The following is a description of a gene set: Abnormal abdomen morphology species: Homo sapiens Human Gene Set: HP_ABNORMAL_ABDOMEN_MORPHOLOGY A structural abnormality of the abdomen ('belly'), that is, the part of the body between the pelvis and the thorax., and this is the list of marker genes: HAVCR2, ABCB11, KIF20A, MTX2, ZEB2, PLAAT3, PALB2, USB1, PDGFRB, AGGF1, NGLY1, HJV, DYNC2LI1, TSC2, RABL3, ASAH1, BCL11A, ADA, LACC1, FGA, SLC7A7, BCL2 (NCBI Gene Id 596), VPS33A, TERT, GBA1, WDR1, MT-ATP8, SLC35C1, COX14, SAMHD1, ERCC8, UNC13D, LTBP3, LYST, G6PC1, LMNA, CCR1, DPM2, GATA2, CD40LG, TLR8, GAA (NCBI Gene Id 2548), FAM111B, PMM2, PIGS, SOX10, CCDC115, CBS (cystathionine beta-synthase), ABCG5, CD27, FANCD2, BRCA1, C2orf69, SPTBN1, NDUFS7, MYO5B, TKT, FBP1, BSCL2, ETFA, ATP8B1, PGM1, CTC1, GNA11, ATPAF2, G6PC3, CYBA, SLC19A1, AMACR, TREX1, NOTCH1, POU2AF1, SPIN4, ALDOB, EPB41, MT-ATP6, LCK, GALM, HBG1 (hemoglobin subunit gamma 1), TRIP13, MKS1, CTNS, TYMS (NCBI Gene Id 7298), SLCO2A1, GLB1, ARG1, IL18BP, PSMB8, ATRX, CD247, RFC2, TMEM67, GUCY2D, LIPA, NAE1 (NEDD8 activating enzyme E1 subunit 1), MCM4, NFKB1, PKLR, EPOR, BCL6, OCLN, SKIC3, SNX10, GPR35, FH, PHKB, HMOX1, RIPK1, CNTNAP2, TNFRSF1B, MYL2, PDCD1, NDUFB10, LIN28B, PIK3CA, TNFSF11, TPP2, TMEM165, VPS37D, CCDC47, GTF2IRD1, SLC25A15 (solute carrier family 25 member 15), POU6F2, ALG2, SLC34A2, NDUFS4, DOCK11, BPGM, HIRA, LYRM4, CYBC1, TSC1, CAVIN1, TNFRSF9, ALG8, MYPN, FOXRED1, PUS7, TRPV6, ARL6IP6, MVK, RNU7-1, SLC2A2, LRBA, MIF, MMACHC, KCNQ1OT1, NAGA, RREB1, ATP5MK, PEX19, BRCA2 (BRCA2 DNA repair associated, NCBI Gene Id 82716), PEX5, NRAS, FASLG, JMJD1C, HAMP, IKZF3, BAP1, ALG13, COX10, HSD3B7, SLC25A13, LCAT, DPM1, DNAJC21, MPV17, ZAP70, BBS12, SLC37A4, EXTL3, ETFDH, ABHD5, B4GALT1, NSD2, DKC1, PTPN11, SPTB, MT-TK, JAK1, PRF1, HNF1A, PIEZO1, FLI1, FOCAD, KDM6A, PHYH, PSMG2, GALK1, C4A, NDUFA1, VPS11 (VPS11 core subunit of CORVET and HOPS complexes), TNFRSF4, SMAD3, CPT2, AGA, SRP54, ABL1, BCR, MT-ND5, BTNL2, YARS1, TMEM70, EIF5A, PEX16, RPS26, MCOLN1, INPP5E, PHOX2B (NCBI Gene Id 8929), PIBF1, KCNN4, SOS1, SAT1, RAB27A (RAB27A, member RAS oncogene family), PEX26, SEC23B, TCF3, NLRP1, NOP10, AKT1, ATAD3A, SOX18, OAS1, CD96, SPP1, ATP7B, PEX2, MT-TL1 (NCBI Gene Id 4567), SOS2 (NCBI Gene Id 96829), ITCH, MT-TN, MAP2K1, SLC2A1, NAGLU, LAMA5, SEC63 (SEC63 homolog, protein translocation regulator), TIMMDC1 (translocase of inner mitochondrial membrane domain containing 1), TERC, GLRX5, ADA2, JAM3, FERMT3, PYGL, LARS2, CARD11, CBL, STAT4, AGL, GNMT, XPR1, PLEKHM1, AKT2, BACH2, CHD7, LARS1, SPIB, STXBP2, CASK, MMAB (metabolism of cobalamin associated B), BAAT, USP53, DLD, PDGFRA, DHFR, LIPE, DLL4, HGSNAT, IRF1, SLC29A3, NCF2, GATA1, BMP2, MT-TV, PRKAR1A, THSD1, GPC4, TGFB1, GPI, WT1, TULP3, TNPO3, AGR2, HSD17B4, LPL, TFE3, GNE, MPL, RINT1 (NCBI Gene Id 60561), NAB2, HACE1, KPTN, LZTR1, EIF2AK3, NDUFAF4, PNP, IFIH1, ASS1, CYP2R1, NUBPL (NUBP iron-sulfur cluster assembly factor, mitochondrial), VPS13A, POT1, EIF4H, TRMU, PEX3, FMO3, GP1BA, SOCS1, NDUFAF3, DZIP1L, TRAC, ICOS, IFT122, BAZ1B, RASA2, GTF2IRD2, SUCLG1, DOCK6, PPARG, ALDH1A2, UFD1, IL6ST, VIPAS39, ATP5F1D, GCLC, IL2RB, STAT1, MRPL3, BUB1B, DCDC2, NR1H4, DNAJC30, HLA-DRB1, FCHO1, H19, SGSH, MS4A1, C1QBP, SH2B3, UROD, CSF3R, NDUFA6 (NCBI Gene Id 4700), COL18A1, IFNG, PRKCD, GEMIN4, TMEM199, KIF1B, ARVCF, MED12, RPGRIP1L, CASR, NDUFS1, UMPS, RNF31, AHDC1, MADD, LRP5, DOCK2, ZIC3, HBA1, PNPLA2, MARS1, PSMB10, MMEL1 (membrane metalloendopeptidase like 1), MET, NAGS, SPINT2, CYP7B1, RTL1, XIAP, PARN (poly(A)-specific ribonuclease), USP18, IL2RA, SLC40A1, PTH1R, FGFR2 (NCBI Gene Id 2263), BUB1, IFT140, IFNGR1, CD81, STAT6, MYD88, NDUFAF5, IL12A, TNFRSF11A, MPIG6B, IDS, CR2, RFXAP, PSMB4, COA8, COX5A, NDUFAF2, KCNJ11, SLC25A1, ABCC6, ABCG8, ADRA2A, TBX1, RIT1, XK, PEX7, ROR2, NPHP3, IL12RB1, NDUFB11, STIM1, PRG4, BUD23, FAT4, MAN2B1, IFT172, FOXC2, ALK, YME1L1, BTD, SLC25A20, KCTD1, SPRED2, RBPJ, NDUFB3, PSMB9, LAT, LSM11, TRAPPC11, AGPAT2, ZFYVE19, TPI1, PIGM, NLRP12, UBR1, MAGT1, EPHB4, ERBB3, RAC2, SEMA4D, SLC4A1, IKBKG, LIMK1, DCLRE1C, MT-ND3, NDUFAF1, ACADVL, VPS4A, LTBP4, PTPN22, RHD, XYLT1, PKHD1, SCO2, MRPS7, GALE, NLRP3, ELN, PEX13, AP3D1, TFAM, ADAMTSL2, STX11, ATP5F1A, PCCA, EARS2, COG7, EWSR1, NDUFS2, SERPINA1, ANKRD55, ZNF699, AP3B1, GNPTAB, CA2, GNS, CCND1, CD19, RHAG, NDUFV2, EPB42, PRDX1, MT-ND1, GBE1, IL2RG, RNASEH2A (NCBI Gene Id 10535), TBK1, TNNT2, CEP57, KRAS, STX5, ANTXR1, KCNH1, HBA2, INSR, TCIRG1, MTTP, PLVAP, KLRC4, SPTA1, NDUFB9, ASXL1, KMT2D, TNNI3 (NCBI Gene Id 7137), MMAA, OTC, ACADM, MCTS1, SLC38A3, PIK3R1, CDKN1C, ARSB, F5, RFX6, PIK3CD, PHEX, MT-ND4, UQCRB, BOLA3, GTF2I, POLG, NFKB2, EOGT, TBL2 (NCBI Gene Id 27203), TALDO1, HMGCS2, ATP5F1E, DIS3L2, TOGARAM1, ITGA6, FAS, SASH3, MRPS28 (mitochondrial ribosomal protein S28), MICU1, SLC30A10, MAPK8IP3, KIT, FUCA1, FBN1, ITK, RTEL1, PCK1, SLC25A19, IL23R, MECOM, FARSA, PHKA2, NDUFA11, ETFB, WDR35, THPO, NPM1, TKFC, CSPP1, ANK1, AUH (AU RNA binding methylglutaconyl-CoA hydratase), ABCB4, ESCO2, TRNT1, ALAS2, CD70, MT-CYB, TLR4, LYN, NDUFV1, HMGCL, MT-TE, RAF1, MPC1, GNB2, MRPS22, NHLRC2, SEC24C, NLRC4, FARSB, RNASEH2B, FOS, SF3B1, CAV1, NEU1 (neuraminidase 1), NPC2, TSFM, BUB3, AKR1D1 (aldo-keto reductase family 1 member D1), MTO1, DHDDS, MFN2, RFT1, COMT, MEG3, GPC3, ADAMTS3, HLA-B (NCBI Gene Id 730410), ATP6AP1, GYPC, CFTR (CF transmembrane conductance regulator), CDAN1, NPC1, CD3E, ERCC4, ITGB4, CLIP2, IRF2BP2, PRKAG2, IRF8, SEMA7A, IRAK1, UROS, OTUD5, NOTCH2, PEX10, ATP6AP2, XRCC4, HMBS, CLCN7, CYP27B1, APOA1, GLIS3, CD55, WRAP53, RBCK1 (RANBP2-type and C3HC4-type zinc finger containing 1), MT-TW, TNFRSF1A, SLC39A4, FOXP3, DNASE1L3, PHKG2, SMPD1, ATP6V1B2, STX1A, CASP8, IRF4, JAK3, COG4, COG5, IL6, ALMS1, ERAP1, GTF2H5, CD28, ABCA12, COX4I2 (cytochrome c oxidase subunit 4I2), DHCR7, KCNQ1, MT-ND2, PIK3CG, DVL1, ZNFX1, PRKCSH, DLK1, NCKAP1L, ALDOA, DDRGK1, COL3A1, PALLD, LMO1, WDR19, SLC6A17, PCCB, RUNX1, CD3D, IL7R, MPI, RNASEH2C, TNFSF15, TET2, SRSF2, PDGFB, HK1, ABCC2, COG1, ABCA1, OSTM1, KANSL1 (NCBI Gene Id 791085), GALT, MDFIC, LMBRD1, GPD1, SURF1, SNX14, TMEM126B, FBXL4, CTNNB1, SLC17A5, DPAGT1, FCGR2A, RFX5, GALNS, PLAGL1, RORC (NCBI Gene Id 6097), NBEAL2, ARPC5, NDUFS8, PEX6 (peroxisomal biogenesis factor 6), PTPN2, YARS2, KIF3B, CIDEC, IFT56, UBAC2, CTSK (NCBI Gene Id 1513), ERCC1, ARL13B, KIF12, SHARPIN, PTPRC, CASP10, PKD2, NDUFA2, SCARB2, SCN4A, SAMD9L, STAT3, MRAS, CDIN1, INPPL1, LPIN2, SC5D, RAG1, GIMAP5 (NCBI Gene Id 55340), ERCC6, CTSA, NOD2, NCF1, FDX2, ACAT1, IARS1, ACOX1, TCF4 (transcription factor 4, NCBI Gene Id 6925), TMEM270, FYB1, TRIM28, HYMAI, RBM8A, TNFSF12, RMRP, GPIHBP1, GUSB (glucuronidase beta), JAM2, NDUFAF8, PEX11B, STEAP3, UCP2, PLEC, GP1BB (glycoprotein Ib platelet subunit beta), ENPP1, CDKN2A, TINF2, IRF5, JAK2, COG6 (component of oligomeric golgi complex 6), ALG1, RAG2, PEX1, CLPB, SCO1, HEXB, FLNC, RHCE, RMND1, TBXAS1, VPS33B, PTEN, MYCN, GFM1, ACTN4, KRT18, TNFRSF13C, TNFRSF13B, SCYL1, TRIM37, FAH, REL, VPS45, MYORG, TCN2, SLC20A2 (solute carrier family 20 member 2), SAA1, G6PD, DHCR24, SKIC2, RASGRP1, IDUA, IGF2, CFAP410 (cilia and flagella associated protein 410), HCK, GRIP1, SH2D1A, CALR, NHP2, PSAP, SUMF1, GP9, POLD1, DNASE2, PEX14, BRAF, LBR, SP110, BMP6, DEF6, FSHR, PIGA, SBDS, POLD3, AFF4, SYK, PIGL, MYBPC3, RRAS2 (RAS related 2), B3GLCT, IL1RN, PEPD, SLC22A5, CYBB, SDHD, TAPT1, POLG2, MST1, PC, WNT5A, KCNN3, RFXANK, SMAD4, ASL, GCDH, ARHGAP31, HPGD, LIG4, HADHA, ATM, PPP1R21, CPOX, HBB, CLDN1 (claudin 1), IL12A-AS1, NCF4, PIK3C2A, FAM111A, ADAR, EFL1, KLF1, REST, MMUT, CTLA4, ALG9, TP53, HBG2, PSTPIP1, PTRH2, APOE, MEFV, APOC2, CC2D2A, NDUFS6, ABCC8, ALPK1, HFE, IL10, MOGS, HYOU1, FKBP6, HNF4A, PEX12, RNU4ATAC, RHBDF2, ABCD3, METTL27, CPT1A, DGUOK, MT-ND6, TUFM, NFKBIA, NEK8, RRAS, CCBE1, NDUFS3